Given this list of marker genes MLXIPL, PFKFB1, PPP2R1B, PPP2R5D, PPP2CA, PPP2CB, PPP2R1A, here is a description of the gene set: PP2A-mediated dephosphorylation of key metabolic factors Human Gene Set: REACTOME_PP2A_MEDIATED_DEPHOSPHORYLATION_OF_KEY_METABOLIC_FACTORS species: Homo sapiens